The following is a description of a gene set: Penetrating foot ulcers Human Gene Set: HP_PENETRATING_FOOT_ULCERS studied in species Homo sapiens, and this is the list of marker genes: F12, SPTLC1, ATL1, SBF2, SPTLC2, ATL3